Given this list of marker genes Csf2rb, Il5ra, Lyn, Il5, Stat5a, Jak2, Csf2rb2, here is a description of the gene set: The series of molecular signals initiated by interleukin-5 binding to its receptor on the surface of a cell, and ending with the regulation of a downstream cellular process, e.g. transcription. species: Mus musculus Mouse Gene Set: GOBP_INTERLEUKIN_5_MEDIATED_SIGNALING_PATHWAY